Given this list of marker genes ABHD14A, HPS4, NFATC2IP, WDR19, NAP1L2, KLRK1, HTRA2, ATP10D, BLK, SCAP, DCUN1D4, COL6A2, COBLL1 (cordon-bleu WH2 repeat protein like 1), LIN7B, HEMK1, ILRUN, CPNE1, IFFO1, ZNF224, ZSWIM8, ICMT, HLA-DQB1, CAPN3, CDK2AP2, CASP4, MAGEF1, RUBCN, SBF1, BACE2, DNAJC16, ZBTB40, IGHA1, PDXDC1, NLRP1, MYBBP1A, ATXN2, ABHD6, SUPT7L, GGA2, SKIC2, LINC00921, RPS6KB2, PIAS4, LRIF1, LPCAT4, ABCD4, ABCA7, NEK9, PHTF1, MOGS (mannosyl-oligosaccharide glucosidase), ZGPAT, NOMO1, WDR59, CIITA, MECP2, CXCR5, HLA-DQA1, TLE1, ITFG2, SAP25, ZNF45, PRKD2, TAF4, TSPAN3, TAF1C, CRELD1, ACTR1B, CXXC1, SEL1L3, HS3ST1, MLEC, NRF1 (NCBI Gene Id 4899), BTN2A1, SEC13, C11orf21, CD2BP2, POLG2, EML2, NPC1, IL4R, CSNK1D, MIA3, P4HTM, NHERF1, DDHD2, ABCB1, SGSM3, PSD4, CEP76, RASSF1, NISCH, CHKB, FAM193A, AHSA1, IL21R, EZH1, SEC24C, PWWP3A, RBM5, APBA3, UCKL1, ADAM28, P3H1, BRD3OS, ARHGAP25, ERBB2, TMCO6, INTS11, PHF20, ACADVL, GTF2H2, GLS (glutaminase), RGS3, IRF3, IVD, AKAP1, SLC5A3, NR3C2, METTL3, LLGL2, FHIP2B, AGAP4, HMCES, DCAF8, GUSBP3, ZNF419, ARIH2, JADE1, MRS2, P2RX5, PUS1, PRSS23, MICAL3, CLK2, ZFP30, SFI1, PLG, ARHGAP45, RABEP2, ZNF133, TESK1, NRCAM, ACAP1, RGL2, SAFB2, CCR6, USP11, TAF5, TRAPPC10, GSE1 (NCBI Gene Id 23199), FADS3, NUP85, PAN2 (NCBI Gene Id 9924), TRADD, PDIA6, GAK, LRCH4, LRCH3, CBX7, PDE4DIP, SUGP2, PILRB, MPHOSPH8, PPOX, PCNX1, NSUN5, MAP4K1, PIGG, RGS14, TOR3A, PCF11, ADRB2, RASGRP2, RER1, NT5C, PTCH1, MED22, here is a description of the gene set: Human Gene Set: GSE6269_HEALTHY_VS_E_COLI_INF_PBMC_UP studied in species Homo sapiens Genes up-regulated in comparison of peripheral blood mononuclear cells (PBMC) from healthy donors versus PBMC from patients with acute E. coli infection. from publication Ramilo O, Allman W, Chung W, Mejias A, Ardura M, Glaser C, Wittkowski KM, Piqueras B, Banchereau J, Palucka AK, Chaussabel D (PMID 17105821) Each infectious agent represents a unique combination of pathogen-associated molecular patterns that interact with specific pattern-recognition receptors expressed on immune cells. Therefore, we surmised that the blood immune cells of individuals with different infections might bear discriminative transcriptional signatures. Gene expression profiles were obtained for 131 peripheral blood samples from pediatric patients with acute infections caused by influenza A virus, Gram-negative (Escherichia coli) or Gram-positive (Staphylococcus aureus and Streptococcus pneumoniae) bacteria. Thirty-five genes were identified that best discriminate patients with influenza A virus infection from patients with either E coli or S pneumoniae infection. These genes classified with 95% accuracy (35 of 37 samples) an independent set of patients with either influenza A, E coli, or S pneumoniae infection. A different signature discriminated patients with E coli versus S aureus infections with 85% accuracy (34 of 40). Furthermore, distinctive gene expression patterns were observed in patients presenting with respiratory infections of different etiologies. Thus, microarray analyses of patient peripheral blood leukocytes might assist in the differential diagnosis of infectious diseases.